Given this list of marker genes KCNJ1, ITGAM, CLCN5, KCNE5, MYO1E, GATA3, NUP37, IFNGR1, TRIM8, COL7A1, PRTN3, ARHGAP24, SLC7A7, JAZF1, DNASE1, ANKFY1, CFHR5, OCRL, LAMA5, MT-TS2, MT-TL1, ANLN, NF1 (NCBI Gene Id 646021), TAPBP, KLRC4, MT-TW, PGM3, IGHG1, ITGB4, STAT4 (signal transducer and activator of transcription 4), IL10, MT-ND6, DNASE1L3, DNASE2, MECP2, TP53RK, EMP2, SLC37A4, SDHD, TREX1, NEK8, HLA-B, NUP107, RET, WT1, COL4A5, BANK1, DNMT3A, FAH, HNF1B, CASP10, KANK2, ACSL4, FCGR2B, MT-TQ, IL12A, MT-ATP6, MT-TH, LACC1, NPHS2, CLCNKB, TLR7, TPRKB, MT-TK, C3, NPHP3, SEC61A1, IRAK1, SDHB, BSND, LMNA, UBAC2, APOE (apolipoprotein E), WIPF1, PXK, FN1, MT-ND4, MYOCD, SPRY2, COL4A3, HLA-DPB1, MTX2, MT-TV, SLC25A11, NOS1AP, PTPN22, SDHC, C1QA, MT-ND1, CFI, MDH2, SCARB2, NOP10, PLEC, ADA, ACTN4, UMOD, TNFAIP3, ITGA3, REN, AVIL, WAS, APOL1, IRF5, WDR73, ERAP1, SLC12A1, COQ8B, AMMECR1 (NCBI Gene Id 9949), NUP93, YRDC, MTRR (NCBI Gene Id 4552), EPAS1, COL4A4, TBC1D8B, TLR4, JAG1, MMP1, PAX2, NUP205, ARPC5, CCR1, INF2, MT-ND3, GLA, FCGR3B, G6PC1, LMNB2, IL12A-AS1, TNIP1 (TNFAIP3 interacting protein 1), CTLA4, TNFSF4, FOXC2, MT-CO1, CR2, C4B, MT-ND2, NPHS1, MMACHC, NUP85, ELP1, GAPVD1 (GTPase activating protein and VPS9 domains 1), IL23R, RNU7-1, MUC1, LMX1B, NUP160, TMEM127, OSGEP, JAK1, ZAP70, MT-CO3, BLK, SPP1, SDHAF2, FH, PLCE1, COPA, FOXP3, PTPRO, FCGR2A, KIF1B, C4A, COQ6, IL6, PDCD1, ALMS1, CEP83, MT-ND5, DGKE, NAA10, SGPL1, FAS, SMARCAL1, NUP133, DKC1, DLST, UBE2L3, CD151, HLA-DPA1, ARHGDIA, CFH, KIAA0319L, COQ2, SOCS1, MEFV, LAGE3, MT-TF, ETS1, LAMB2, NARS2, CD2AP, LPIN2, TRPC6, ZNFX1, KIRREL1, MIF, WDR4 (NCBI Gene Id 55896), DAAM2, SOX18, WDR19, MME, MAGI2, VPS33A, PRKCD, GON7, VHL, SLC41A1, MT-CO2, HLA-DRB1, MAX, SDHA, CD81, CRB2, SLC12A3, FASLG, here is a description of the gene set: Any anomalous structure of the renal corpuscle, which is the initial component of the nephron that filters blood. The renal corpuscle consists of a knot of capillaries (glomerulus) that is surrounded by a double-walled capsule (Bowman capsule) that opens into a renal tubule. Abnormal renal corpuscle morphology Human Gene Set: HP_ABNORMAL_RENAL_CORPUSCLE_MORPHOLOGY studied in species Homo sapiens